The following is a description of a gene set: Genes containing one or more binding sites for (Relb) in their promoter regions (TSS -1000,+100 bp) as identified by GTRD version 20.06 ChIP-seq harmonization. Mouse Gene Set: RELB_TARGET_GENES from publication Yevshin I, Sharipov R, Kolmykov S, Kondrakhin Y, Kolpakov F (PMID 30445619) species: Mus musculus, and this is the list of marker genes: Gm5617, Isy1, Spsb2, Lncpint, Cenpl, Gosr2 (NCBI Gene Id 97688), Gpr180, Zc3hav1, Bmf, Tpm3, Yars2, Arl8b, Cdkn2a, Nlrp3, Rnf19a (ring finger protein 19A), Fcrl1, Rarg, Zfp383, Bcas3, Rnf10, Actn1, Sh2d6, Blnk, Ipo7, Gbp4, Mgat4b, Gm13270, Xpo4, Arap1, Stx18, Eif4enif1, Slc1a2, Rab28 (NCBI Gene Id 70035), Sec61g, Cep83os, Peds1, Trps1, Gm9246, Ro60, Katnb1, Flcn, Rpl13, Slc7a2, Nr6a1, AI504432, Eif4g1, 2700049A03Rik, Lrch3, Rubcnl, Pimreg, Lhfpl4, Mir8112, Zfp661, Morc3, Fbxl12os, Rnf121, Gm20257, Prkcd, Polr1a, Shcbp1l, Ccdc88b, Irf9, 5031415H12Rik (NCBI Gene Id 75984), Dctn6, Rad9b, Nedd4l, Cox18, Actbl2, Hsdl2, Fbxo34, B230217C12Rik, Kif5c, Pgghg, Elk3, Zdhhc17, Zmym6, Zfp574, Ap4s1, Ptpn3, Polr3a, Ing4, Gdap2, Bcl2a1c, Cdpf1, Mlkl, AW146154, Nhlrc2, Zfp408, Cog7, Pan2, Gm4221, Nufip1, Ccng2, Or14m1-ps1, Cnih4, E2f4, Etv6, Dusp1, Rnu11, Ikzf5, Asxl2, P2ry13, Sh3bp5, Cd33, Il3ra, Zmynd12 (NCBI Gene Id 332934), Zbtb45, Man1a, Cyth1, Nab2, Sphk1, Ccnd3, Susd3, Atp2c1, Sephs1, Mrpl44, Rnf169, 6030452D12Rik, Slamf7, Zfp607b, Calm1, Nkiras2, Foxj3, Yy1, Fxyd5, E330011M16Rik, Gemin2, Dnajc10, Plin2, Stx11, Fpr1, Ccdc50, Pik3r5, Gm5129, Igsf6, Ankrd16, Gtf2h2, Arih2, Eml6, Pim1, Serf2, Mrrf, Cfdp1, Nudt5 (NCBI Gene Id 53893), Trim6, Nudt17, Inka1, Mynn, Oser1, Fbxw2, Kpna7, Nrf1, Efhd2, Pelo, Ska3, Mir22hg, Vcf1, Krcc1, Rexo4, Mir1893, Slc4a1ap, Zc3h7a (zinc finger CCCH type containing 7 A), Synj2, Ergic1, Snrpe, Zfp617, Fbxl18 (NCBI Gene Id 231863), Gm2065, Ece1 (endothelin converting enzyme 1), Hcn3, Gm22489, Tnfsf4, Sestd1, Taf13, 2310001H17Rik, Pnpla2, Smpdl3a, Adap1, H2ac5-ps, Pkn1, Top3a, Gba2 (glucosidase beta 2), Slc25a12, Slc44a1, Tor1aip2, A530013C23Rik, Ccr5, Rpa3, Trim33, Immt (inner membrane protein, mitochondrial), Entpd7, Dusp5, Gm26225, Slc25a40, Ccdc17, Mir8101, Zdhhc7, Dock10, Mir155hg, Cd200r4, Ankrd13c (NCBI Gene Id 99810), Pnpt1, Uck2, 1700084C06Rik, Gas5, Aldh18a1, Trim30a, Mtrf1l, Slc7a11, Egln2, 1700122E12Rik, Eif4e, Arl10, Ascc3, Cd300a, Ptpn2, Cfap68, Rbms1, Emc7, Zhx2, Rab18, Nup85, Gm11870, Nxpe3, Cct5, Ak5, Ifnlr1, Lyrm4, Snord2, Actb, Anp32a, Oas1c, Atp8a1, Adprh, Pilrb1, Pcgf5, Il7, Mir142, Slc26a2, Atg9a, Ppdpf, Mir7050, Rbm8a, Aurkaip1, Tfg, Pdk1, Bmt2, Mrpl55, Prkce, Lrrc49, Polr2a, C3, Casp4, Pdzd9, Gm6209, Tmbim4 (transmembrane BAX inhibitor motif containing 4), B230208H11Rik, Mir425, Trappc6a, Mlec, Cep104, Hadhb, Cux1, Cactin, Ago3, Lsg1, Rbbp5, Tmem59, Gripap1, Tcirg1, Plec, Golga5, 2810001G20Rik, Zc3h4, Ccnt1, Mis18bp1, 5430405H02Rik, Wasf1, Axl, Nrp2, Nuf2, Isl2, Ddhd2, Pmel, Kbtbd2 (kelch repeat and BTB (POZ) domain containing 2), Mplkip, Ccdc97, Nr1d1, Parp16, Zbtb37, Wdr1, Kcnab2, Ppef2, Ginm1, Elof1, Psmc3, Smcr8, 1700007L15Rik, Zfp738, Gm24576, Vps53, P2ry10, Ube2s, Snord49b, Itsn1, Ubald1, Tmem41b, Stk10 (serine/threonine kinase 10), Mtg1, 1110019D14Rik, Slc45a4, Gtpbp1, Arhgap25, Creb3, Mien1, 2410002F23Rik, Ifit1, Scaf8, Ddx5, Gm26708, Ttc4, Parp11, Fam210a, Gm7266, Spag9, Pcmtd1, Zfp703, Fgf9 (fibroblast growth factor 9), Rnf181, 4933434E20Rik, Ubfd1, Rmdn1, Maea (NCBI Gene Id 80495), Rasa2, Dyrk3, Pbrm1, Pknox1, Tmem33, Etf1, Gm27042, 1810059C17Rik, Hcfc1, Arhgap10, Fam8a1, Gsk3a, Clec5a (C-type lectin domain family 5, member a), Ccnd2, Gbp3, Rnase6, Nxt2, Arf4, Tmem219, Usp1, Rgs12, Ggnbp2, Rny1, Ptges2, Atpsckmt (NCBI Gene Id 68073), C130050O18Rik, Atg5, Drg2, Foxp1, Adam15, Olr1, Gm26728, Gspt1, Zfp770, Emp1, Mki67, Rac1, Nr3c1, Nrg4, Dus2, Tlr9, Sqor, Gm10459, Unc119, Cxcr5, Lhpp, Leprot, Ggn, Mettl5os, Nusap1, Esd, Stard5, Uba5, Nfkb1, Pomgnt1, Vcan, Nop56, Ugt1a6a, Cdc42se1 (NCBI Gene Id 99930), Wnt11, Plscr1, Cwc27, Gstcd, Alas1, Extl1, 1700065D16Rik, Haus8, Pdcd6ip, Dhcr7, Gm19739 (NCBI Gene Id 102638335), Mir8120, Gm4890, Polr3gl, Hspd1, Abcc5, Pfkp, Fblim1, Kctd10, Gabpb1, Tchh, Idh3g, Irak3, Fjx1, Cdk5rap1, Nfkbid, Slfn4, Etfb, Oasl2, Larp7, Ptprj, Syne3, Slc9a8, Fbxl12, Tbce (tubulin-specific chaperone E), Gm13814, Traf7, Ctsl, 1700034P13Rik, Id3, Ptp4a1, Xntrpc (NCBI Gene Id 102443351), Gm26224, Zfp655, Klhdc8b, Arid4a, Ndc1, Trmt5, Bpnt1, Gm22581, Pard6b, Pigv, Spata6, Gm11527 (predicted gene 11527), Calhm4, Dusp2, Birc3, Ptprv, Clint1, Rpl9-ps1, Ppp2r2d, Gm13546, Pnrc1, 1700064H15Rik, Cab39, Arfgef2, Gm23130, AF357399, Tmem222, Ppp1r12a, C130046K22Rik, Slc17a5, Marco, Cflar, Srsf4, Setd3 (NCBI Gene Id 77715), Mnt, Zgrf1, Ubl7, Mlxip, Nfkbie, Ccl6, Gm6610, Synj1 (NCBI Gene Id 77939), Dusp13b, Coq4, Irf8, Gm10509, Bcl2l11, Dlgap4 (NCBI Gene Id 98882), Ubap2l, Oip5, Otud7b, 4833439L19Rik, Ptbp1, Stx1b, Batf2, Mllt10, Marf1, Atp6v0b, Rplp1, Jarid2, Cep162, Bach2it1, Gm4081, Mrps21, Coro2a, Mtx1, Atf3, Med27 (NCBI Gene Id 98820), Cand1, Atp6v0d1, Rbm4, Ccdc102a, Ticrr, H2bc21, Rps27l, Zmym2, Gm36527, Trp53, Phkb, Itpkb, Fam168b, Slc38a9, Psmd14, Cd63, Dlec1, Aimp1, Gm25323, Asb6, Atxn7l1, Fibp, Acss2, Poll, Vhl, Gna15, Hnrnpk, Dhx35, Nudt6, Abi1, Yju2b, Scaf1, Afg2a, Naa15, Cped1, Arih1, Abt1, Actr2, Nfkb2, Acod1, Mir191, Degs1, Mrfap1, Cntrob, Pms1, Ccdc127, Slfn10-ps, Zmpste24, Ahsa1, Rabgap1l, Gpbar1, Tceanc2, Dcaf11, Adgrg6 (adhesion G protein-coupled receptor G6), Usp49, Git2 (NCBI Gene Id 80654), Epc1, Siglecg, Sdad1, Tbc1d4, Tpp2, Rtp4, Mir6359, Arl6ip1, Tnfsf13os, Mfsd12, Nvl, Glmp, Ptprs, Klf6, 4930580E04Rik, Kat7, Spcs2 (NCBI Gene Id 66624), A630072M18Rik, Clcn3, Trub2, Kcnk10, Mthfd2l, Nme6, Gm12301, Mir6935, Zfp184, Usp32, Nbeal1, Ikzf2, Tmem69, Acadsb, Mepce, Sppl2a, Zcchc17, Klhl36, Per2, Maip1, Ufsp2, Rfx1, Colgalt1, B3gntl1, Ufm1, H1f8, Snord58b, Znrf1 (zinc and ring finger 1), Amigo2, Rps15a, Opa1, Gucd1, 9430015G10Rik, Snf8, Otud4, Mad1l1, Ndufaf1, Plag1, Gm5150, Lrch4, Med29, Tanc1, Zyx, Cryl1, Cttnbp2nl, Kdm4a, Rps5, Sec23a, Slc25a45, Rars2 (arginyl-tRNA synthetase 2, mitochondrial), Pigc, Ctnna3, Gm26787, Myef2l, Hdlbp, Mafb, Cd200r3, Ap3b1, Tshz1, Shtn1, Zfp169, Nudt16, Creb1, Slfn9, Atp13a1, Ido2, Cd2bp2, Apba3, Akt2, Kmo, Lyzl4, Arhgap22, Lrrfip2, Fas, Ftl1, Tmppe, Lrrc57, Mgat4a, Gm12275 (NCBI Gene Id 115487780), Nsf, Zfp1, Cenpc1, Gm13425, Slc25a25, Nfe2l1, Rps2-ps11, Mmab, Arfgap3, Fgr, Ckap5, Ccdc180, Csrnp1, Trappc1, Psph, Snap29, Akna, Arhgef2, Fcgr4, n-R5s41, Hnrnpa0, Spice1, Mmp9, Kdm7a, Lrrk1, Cnksr3, Rps29, Tes, Furin, Wrap53, Rpl7a, Tmem232 (NCBI Gene Id 381107), Plpp1, Gna13, Nt5dc3, Gm13620, D330050G23Rik, Gm3807, Smad7, Grk3 (G protein-coupled receptor kinase 3), Gm26885, Ppil3, Erap1, Nedd4, Cpeb4, Nudt1, Lgals3bp, Dennd4b, Rheb, H3c2, Baz2a, Rmc1, Mef2c, Cct2, Sun1, Ap5s1, Prr13, Zwint, Vsir, Wdfy1, Blcap, Ppm1a, Nop16, Poglut2, Mrpl4, Socs2, Eif1ad, Edrf1 (NCBI Gene Id 72581), Ociad1, Itpkc, Tyw5, Gm11613, Ccar2, Serpinb12, Bclaf1, Mphosph8, Gm2453, Gm10851, Slc15a3, Gm26608, Map2k3os, Acad11, Mcemp1, Smarcal1, Cyb5a, Ints10, Tpr, Hs2st1, Ate1, Ldb1, Gm22357, Zbtb18, Dglucy, Lgi4, Vps45, Tmem106b, Htra1, Midn, Pex13, Mgme1, Il2rg, BC064078, Gem, Vim, Mir155, Wif1 (Wnt inhibitory factor 1), Fmc1, Gm16096, Prdx1, Sptan1, Ptx3 (NCBI Gene Id 99687), Myo1g, Cpt1a, Kit, Tm9sf3, Klf13, Il6st, Rps6, Insig2, Amacr, Zfp263, Gen1, Fchsd1, Haao, Atp5f1c, Atp5mc1, Rad50, Braf, Eed, Nap1l4, Dnajc7, Dpcd, Zfp846, Tlcd1, Stx4a, Tal1, Cog1, Cdiptos, Ift56, Srfbp1, Dyrk2, Zdhhc6, Zfp644, Washc3, Txnip, Nek8, Styxl1, Klf7, Hscb, Hfe, Rubcn, Galt, Traip, Dtx4, Lypla2, Ssmem1, Raf1, Gdf9, Cytip, Hapstr1, Nol10, Cxcl2, Pik3cb, Hcls1, Vasp, Ndufaf8, Slc9a1, Zfp26, Pih1d1, Haus2, Sertad3, Zfp397, Zfp318, Gm25878, Ppp2r5c, Ctsa, Emc1, Tlcd3a, Eif4a2, Ciao2a, Set, Trdmt1, Arhgdib, Ndufaf3 (NADH:ubiquinone oxidoreductase complex assembly factor 3), Zfp472, Dstn, Jak2, Serpinb9, Efcab9 (NCBI Gene Id 73944), Ehd1, Mcfd2, Gm5069, Polg2, Msantd2, Pym1, Cfap96, Ncoa2, Phf20, Gm26812, Mllt11, Paf1, Csf2rb2, D5Ertd579e, Dennd10, Lmna, Cdan1, Hlx, Smim27, Stag1, Gm28535, H3c3, Ncoa3, Tef, Nae1, Fbxo22, Med17, Zfp87, Ppfibp2, Xrcc4, Spred1 (NCBI Gene Id 99293), Cebpg, Sod2, Tnpo1, 9330136K24Rik, Gm25364, Rtn4, Ubn1, Ucp2, Birc6, Clec4b1, Ncoa6 (NCBI Gene Id 56406), Ino80dos, Harbi1, Lrp11 (low density lipoprotein receptor-related protein 11), Tmsb4x (thymosin, beta 4, X chromosome), Pan3, Wdpcp, Grk2, Mgrn1 (mahogunin, ring finger 1), Znrd2, Tex48, Tnfaip3, C530005A16Rik, Paip2, Gpr176 (NCBI Gene Id 381413), Sigmar1, Gm29243, Ankrd13a, Usp53, 0610040F04Rik, Dnaja1 (DnaJ heat shock protein family (Hsp40) member A1), Oxsm, Nfkbia, Gtf3c6, Tmem38a, Use1, Gm26588, Plgrkt, Parp3, Ccdc13, Mapre2, AW495222, mt-Tp, Ptgr1, Ptcd3, Plppr4 (NCBI Gene Id 52835), Nrbp1, 1700067G17Rik, Zfp148, Vdac1, Pacsin2, Mtnap1, Smim7, Slc29a2, Tbc1d9b, Pard6a, Cacna2d1, Ubl3, Clec2d, Eif3l, Polh, 3000002C10Rik, Rab3c, Traf1, Cdca2, Mir22, Arid5b, Ckap2l, Arhgap27os1, Akap13, Junb, Ibtk (inhibitor of Bruton agammaglobulinemia tyrosine kinase), Ifrd1, Tnpo3 (transportin 3), Pafah1b2, Maco1, Cic, Cldn1 (claudin 1), Nub1, Rpl13a, Tfcp2, Ccl3, Auh, Tmbim6, Gm13778, Fam53c, Psen2, Chpf2 (NCBI Gene Id 70272), Gm15133, Pgap2, Fra10ac1 (NCBI Gene Id 70567), Gm38247, Slc35a5, Gprc5a, Fnbp1, A830005F24Rik, Psd4, Irak2, Trmt10c, Uqcr10, Hnrnpul2, Col15a1, Ubr4, Arhgap26, Runx1, Dph6, Ube3b (ubiquitin protein ligase E3B), Map2k7, Chchd7, Gm16638, Il4i1, Gm12059, Gm29487, Dipk1a, Supt5, Gm24067 (predicted gene, 24067), Suv39h2, Prkag1, Fam149b, E230013L22Rik, Herc4, S100a1, Notumos, Tmem270, Mfsd14b, Chd2, Mterf4, Rbm48, Relt (NCBI Gene Id 320100), Atg10, Usf1, Isca2, Tex264, Gse1, AI480526, Gabpb2, Anapc13, Snrnp40, Alg9, F730043M19Rik, Hexim1, Septin2, 3110040N11Rik, Tlcd2, Srsf9, Tmem192, Clasp1, Ino80b, Rad54l, Spink10, Lrrc8c, Bhlhe40, Eif5b, Mpv17, Txnrd1, Ercc6l2, Itfg1, Sumo1, Prkar2a, Arid4b, Plekha4, Plekho1, BC035044, Srgn, Zc2hc1a, Gla, Gm15987, Dennd4a, Tnfaip2, Pals1, Dusp28, Ttc21a, Il23a, Lrif1, Tcp1, Mir1956, Zfas1, Borcs6, Tuba4a, Dnase2a, St7l, Retreg1, Cert1, Slpi, Supt7l, Slc37a3, Znfx1, Hes2, Rhob, Washc2, E230029C05Rik (NCBI Gene Id 671286), Dph5, Tmem123, Nek6, Hnrnph2, Gmcl1, Mir1931, Nqo2, Morn2, Ino80d, Snord68, Gm25663, Ugp2, Dnajc14, Aff1, Dock5, Trmt112, Atp5pd, Man2a1, Cryz, Usp37, Neurl3, Stx3, Ncf4, Lpin2, Zbtb11os1, Alyref2, Skil, Ptpn12, Ctrc, Arl2, Bbc3, Kcnab1, Ccdc15 (coiled-coil domain containing 15), Elovl7, Wdr3, Grcc10, Ift140, Malat1, Neurl2, Nsmaf, Fndc3a, Flicr, Gm19774, Pgam1, Dusp14, Nmt1, Telo2, Cdc40, Fdx2, Gm2287, Fancb, Ccl22, Abcf3, Mir1927, Gbp8, Plcxd2, Rnf149, Dusp7, Tmem68, Mir1938, Usp38, Gm23042, Scarna2, Tmem63a, Rnf24, Dbil5, Rmi1, Gm12359, Ccl9, Mcm7, Hsp90b1, Samd8, Pde4d, AW112010, Pofut1, Gpnmb, Gm15931, Gstt3, Rbbp9, Nek10, Inpp4a, Slbp, Tmem39a, Gm10642, Ndufb3, Xbp1, Atp6v1f (ATPase, H+ transporting, lysosomal V1 subunit F), Kmt5a, Pla2g4a, Accs, Ttc17, Septin11, Sh3glb1, Opa3 (NCBI Gene Id 403187), Tbck, Gask1b (NCBI Gene Id 99844), Gm16712, Crem, Rapgef2, Cep68, Cop1, Dtnb, Men1, Atg16l2, Mok, Slc38a1, Thrap3, Mrps34, Zc3h18, Atf1, Gm28809, Etv1 (NCBI Gene Id 14009), P4hb, Gm24457, Arhgap1, Slc35b2, Rhoq, Ccdc47, Mettl26, Cbx7, Stradb, Ndufs8 (NCBI Gene Id 225887), Atp6v0a1, Bcl3, Hmgcr, Eme1 (essential meiotic structure-specific endonuclease 1), Mrps27, Aasdh, Ppp2r5d, Picalm, 2810405F17Rik, Lin7c (NCBI Gene Id 99335), Scd4, Poglut1, Rnf145, Gmfg, Prpf4b, Mcf2l, Fastkd3, Dclre1a, Ublcp1, Trappc10, Zfp217 (NCBI Gene Id 99438), Zbp1, Tti2, Uba7, St3gal3, Gm22186 (predicted gene, 22186), Spred3, Mrps5, Surf6, Abr, Wee1, 4930515G01Rik, Slc25a4, Gm11292, Mef2a, Cmss1, Slc16a1, Zfp61, Gsto2, Piwil4, Dcaf8 (NCBI Gene Id 98534), Slc27a2, Atf2, Ecd, Glg1, Thumpd3 (THUMP domain containing 3), Gm5544, Gm20491, Timm21, Gm22711, Gpr137, Vrk2, Fdxacb1 (NCBI Gene Id 382137), 1700003G18Rik, Ube2e1, Mrps7, Mir223hg, Snord104, Ubac2, Irf5 (NCBI Gene Id 27056, interferon regulatory factor 5), Orm2, 1810062G17Rik, Gt(ROSA)26Sor, Or5k8, E130317F20Rik, Chmp5, Gm13641, Armc9, 2310010J17Rik, B3galnt2, Gm13077, Gm17089, Mtf2, Gbp9, Tjap1, Mir8105, Tamalin, Tnks, Lcorl, Rnf31, Rpl30-ps6, Dhx40, Cx3cr1, Clptm1, Ssh2, Idi1, Tmem167, Hnrnpd, 4930518I15Rik, Stap1, Amz2, Homer1, Mpc1 (NCBI Gene Id 70697), Klhdc4, Gm37383, Gan, Fcgr2b, Tmem266, Orc3, Alkbh3os1, Prr33, Mrpl18, Kpna1, Bcl7c, Cdk2, Calr, Dnajc5, Ccnl1, D330041H03Rik, Sec63, Ints2, Rnu7, Triobp, 2810454H06Rik, Nsmce2, Banf1, Gm10433, Ccdc71 (NCBI Gene Id 72454), Spen, Ptgs2os2, Maf1, Cxcl10, Gm15736, Zfp608, Tbk1, Lockd, Abcg4 (ATP binding cassette subfamily G member 4), Atf7ip, Mir484, 1110002J07Rik, Sbf2, Mir7228, B3galt6, H3c4, Zmat5, Bad, Arid1a, Pus10, Vti1a, Zcwpw1, Rsrp1, Gm10010, Pfkfb4, Ncor2, Zfp93, Cpsf7, Hip1, Ppp1r3f, Mir21a, Taf6, Acsf3, Mrpl20, Mir7009, Ubl5, Evi5, Bcl2l1, Ift74 (intraflagellar transport 74), Urm1, Mrps16, Acad8, Mir1949 (NCBI Gene Id 100316700), Actl6a, Pon3, D730045B01Rik, Uap1 (UDP-N-acetylglucosamine pyrophosphorylase 1), Myl4, Ptk2b, Junos, Meig1, Usp4, Zfp719, Il18rap, Rbm22, Dcun1d5, Ipmk, Stxbp6, Gm20465, Selenok (selenoprotein K), Mars1, Ttc39aos1, Igkc, Gadd45g, Ncoa7, Eif3a, Itgb3bp, Gm25855 (NCBI Gene Id 115489078), Il1b, Zfp106, Tex261, Mark2, Tmed1, Daam1, Cd53, Efcab7, Comtd1 (catechol-O-methyltransferase domain containing 1), Ptcd2, Gm266, Rin3, Chmp7, 5430400D12Rik, Selenof, Snrpa1, Uqcrq, Atp6v0c, Gm24195, Tbpl1, Usp40, Gtf3c5, Hivep1, Cycs, Tent4b (terminal nucleotidyltransferase 4B), Ppid, Kptn, Ebag9, S100a4, Itgam, Ube2q1, Denr, Aim2 (absent in melanoma 2), Per1, B930036N10Rik (RIKEN cDNA B930036N10 gene), Sugct, Zfp324, Luc7l, Ubash3b (NCBI Gene Id 72828), Fth1, Trpv2 (NCBI Gene Id 22368), A930012O16Rik, Iba57, Fabp12, Ctsc, Gpr35, 4930570N18Rik, Espl1, Tgif1 (NCBI Gene Id 21815), Rps6ka1, Mysm1, Adcy7, Grn, Cfl1, Slc33a1, Gnas, Relb, Acbd3, 4931422A03Rik, Paxbp1, Cenpa, Stat6, Vwf, Kctd9, Cyp4f13, Plekha2, Snord49a, Disp2, Mtmr12, Spmip7, Klrk1, Cd40, Mx2, St7, Ccr9, Glipr1, Gpr84, Trmo (tRNA methyltransferase O), Hells, Myc, Mrpl39 (mitochondrial ribosomal protein L39), Fnip1, Raph1, Ap3s2, Caprin1, Psmb3, Clec4a2, Brd7, Cast, Ppfia3, Rpl36-ps2, Kif1a, Gm22748, Snord60, Plek, Ccdc33, Ngly1, Txndc15, Gm6283, Plagl2, Clcc1, Flna, Ppp1r15a, Pcbd2, Eea1, Rgp1, Gpbp1l1, A630072L19Rik, Senp3, Fam162a, Vmp1, Ctbs, Hdac5, Fbh1, Cd37, Klhdc9, Ccl17, Or10aa1, Tpk1, Utp3, Mir147, Snord14a, Dffb, Zfat, Dst, Tbkbp1, Snrpd3, Kmt5c, Atosb, Spry4, Gm15473, Ly6e, Knl1, Fam193b, Zfp799, Cd48, Oas1b, Sumf2, Klhdc10, Cbl, Dusp22, Gid8, Ralgds (NCBI Gene Id 19730), Gm22809, Safb2, Ubb, Timm9, Cdh23, Prdx5, Itga5 (NCBI Gene Id 16402), Zc3h11a, Ube2d2a, Galnt9, Naa16, Alkbh1, Lars2, Cdc42ep2, 2310033P09Rik, Ado, Gm11520, Tln1, Mtdh, Zfand1, Psme2, Gpr85, Gm13855, Srek1ip1, Cyrib, Hk1os, Nol6, Ggt7, Serpina3f, Neat1, Ralbp1, Gng2, Vipas39, Asap1, Tmigd1, 1810055G02Rik, Tsku, Dcstamp, Ppp1cc, Rufy3, Rreb1, Mir1945, Zpr1, Smarcc2, Lyrm1, Mrtfa, Rsph3b, Zfp516 (zinc finger protein 516), Sacm1l, Cdkn2c, Tcf3, Egr2, Wdr83, Pla2g7, Xpo6, Tbc1d31, Mab21l3, Asxl1, Nostrin, Dzip3, Mir5619, Rttn, Cdc42ep4, Gm16675, Heg1, Txnl1, Clpx, Stk11, Kctd2, 1700055D18Rik, Lair1, Fnbp4, Gm12273, Npc1, Hyou1, Nod1, Tm9sf4, Nsmce1, Gm27252, Oga, Ccdc87, Srgap2, Gm22488 (predicted gene, 22488), Tmem116, Tmed7, Phf21a, Il10rb, Runx2, Mbnl1 (NCBI Gene Id 56758), Letm2, Rptor, Kin, Vdac3, Socs3, Cxcl9, Pds5a, Slc36a4, Aph1a, Gm27003, Upf2, Rell1, Rgs18, Prdx6, Stard7, Gm20605, Grk4, Gm10709 (predicted gene 10709), Gm26782, Nox1, Jmjd1c, Eml4, Zc3h12a, Rrp9, Gm807, Gsr, Thoc1, Trim24, Tmcc3, Mogs, Wdr81, Sh3bp4, Ktn1, Usp48, Timmdc1, Igf1, Btg2, Usp2, Lcp1 (NCBI Gene Id 52646), Nmral1, Tyrobp, Kdm3a, Lratd2, Hmox1, Heatr5b, Sharpin, Dcun1d3, Hycc2, AV039307, Tifa, Capns1, Cdc26, Hacd4, Atg4b, Gm7804, 4632404H12Rik, Ap4m1 (NCBI Gene Id 71646), Rapgef4os1, Dmxl2, C3ar1, Rsu1, Hk1, Gm1965, Manbal, R3hdm2, Nfkbiz, Ptrh2, Snx10, S100a13, Ralgapa2, Fdxr, F10, Gtpbp3 (NCBI Gene Id 70359), Wnk1, Cfap43, Parp8, 2900089D17Rik, Nccrp1, Pak4, Spcs2-ps, 1700041G16Rik, Med6, 1600020E01Rik, Mtrex (Mtr4 exosome RNA helicase), Ttbk2, 5031425F14Rik, Fscn1, Atf7, Trnt1, Eme2, Acaa1a, Frmd8os, H2bc3, A930005H10Rik, Ldha, Mmp12, Tmco4, Nck2, Tcf7l2, Orc1, Fos, Ampd2, Lrrc63, Ptpn1, Gnpda1, Ptger4, Serpina3g, Gm16685, Nuak1, Parp14, Pkmyt1, Sh3d21, Stat5a, Tor1aip1, Yipf3, Ube2g2, Chfr, Rbm27, Gbp5, Ccdc18, Plekhj1, Oasl1, Dars2, Slc11a1, Rpl17, Tab2, Traf3ip3, Tspoap1, Pold3, Ano10, Mob1a, Hepacam2 (HEPACAM family member 2), Spry1, Abhd10, Zfp113, Arfrp1, Stk40, Nfx1, Shkbp1, Adar, Trim13, Pdhb, Mettl5, Tgs1, Ndel1, 6030442K20Rik, Cdkl4, Cers6, Gm22013, Rab5c, Gm25703, Gm2670, Icam1, Frmd4b, Rps15a-ps5, Cat, Gm13033, Arf6, Ndufaf7, D030056L22Rik, Psma1, Wdr83os, Ogfrl1, Fem1a, Coq3 (NCBI Gene Id 97143), Zscan12, Cdc23, Fnip2, Elmo2, Ppp2r1a, Sinhcaf, Arpin, Gm6410, Ttc9c, Cish, Ramacl, Dnajb6, Socs5, Cd82, Nsrp1, Ap1g1, Il2ra, Ppp3r1, Btaf1, Bivm, Tubb2a, Vipr1, H2bc18, Atp5mc3, Bola1, Hnrnpu, Zbed6, Mir423, Ppm1k, Xndc1, Abca8b, Ms4a6b, Dck, Fndc3b, Fem1b, Dgkz, Sh3bp1, Hnrnpa3, 0610039K10Rik, Tmem94, Hexim2, Prx, Ubr5, Rela, Ppcs, Car13, Mvk, Elmo1, Zfp110 (zinc finger protein 110), Sypl2, Snord13, Dynlt4, Csgalnact2, Hgsnat, 4933431K14Rik (RIKEN cDNA 4933431K14 gene), Gtf2a1, Hsd17b12, Nucks1, 5530601H04Rik, Frg2f1, Actg1, Gm16062, Gmeb2, Rel, Zfp809, Tug1, Jun, Ttc39a, Txndc9, Tmem242, Ncf1, Gm24044, Prpf38b, Icam4, Ifnb1, Snx11, Ccdc159, Ikzf4, Pik3ap1, Il1rn, Klk1b11, Golt1b, Polr1c, Odr4 (odr4 GPCR localization factor homolog), Impa2, Stx16, Rpl21, Itgb5, 1700010K24Rik, Cip2a, Gm22107, Slc43a2, Slc35a3, Fgf23, Mdfic, Kcna3, Gpr19, Naa60 (NCBI Gene Id 74763), Fbxo42, Pts, Cab39l, Gm10373, Pisd, Rnf170, G3bp1 (G3BP stress granule assembly factor 1), Tns3, Edf1, Arhgap11a, Gm20492, Gpbp1, Rab21, Slirp, Gm24728, Acd, Gm29340, Mfsd1, Fis1, Hltf, Szrd1, Rps7, Orai2, Csde1, Cdc123, Med13, Mir7655, Slfn2, Qser1 (NCBI Gene Id 99003), Glb1, Gm16731, Fyco1, Slc16a3, Rcbtb2, Tubb6, Gm14221, Dop1b, 9130230N09Rik (RIKEN cDNA 9130230N09 gene), Rps27a, Psma6, Ivns1abp, Ddx42, Pla2g15, Ppif, Tmem198b (transmembrane protein 198b), Pdlim2 (PDZ and LIM domain 2), Ero1a, Prex1